The following is a description of a gene set: Mouse Gene Set: MIR_376B_5P_MIR_376C_5P species: Mus musculus from publication Chen Y, Wang X (PMID 31504780) Genes predicted to be targets of miRBase v22 microRNA mmu_miR_376b_5p, mmu_miR_376c_5p in miRDB v6.0 with MirTarget v4 prediction scores > 80 (high confidence targets)., and this is the list of marker genes: Heca, Zfp609, Gm20939, AI593442, Esp34, Apbb1ip, Cd200r2, Serpinb3a, Eid1, Cd84, Ttc9c, Psg16, Mbnl2, Sema6d, Gapt, Rp1l1, Stmn1, 2310009B15Rik, Ptgs2, Adgrg2, Scrg1, Arid2, Tmem138, Met, Zfp114, Irf2bp2, Nrn1, Magi2, Serpinb3b, Zfp1, Tmed8, Flt1, Plxnc1, Cd200l1, Rnf2, Wee1, Serpinb3c, Slitrk1, Ptprt (protein tyrosine phosphatase receptor type T), Ifih1, Syt4, Mcm3, Rasa1, Ift88, Bmp6, Layn, Zbtb33, Alox12, Nhlh2, Prl7b1, Elp3, Dazl, Hsf3, Cpeb3, Neu2 (neuraminidase 2), Zfp128, Secisbp2l, Fzd8 (NCBI Gene Id 14370), Rnase4